The following is a description of a gene set: species: Homo sapiens Human Gene Set: HP_ANISOMETROPIA Anisometropia Inequality of refractive power of the two eyes., and this is the list of marker genes: CYP1B1, POGZ, AP1G1, CLCN3, TEK, RERE, MYOC, FGFR2, SLC35A2, KRAS, LTBP2 (NCBI Gene Id 83981)